The following is a description of a gene set: studied in species Homo sapiens Human Gene Set: GOBP_BLASTOCYST_DEVELOPMENT The process whose specific outcome is the progression of the blastocyst over time, from its formation to the mature structure. The mammalian blastocyst is a hollow ball of cells containing two cell types, the inner cell mass and the trophectoderm. The blastula follows the morula and precedes the gastrula in the developmental sequence., and this is the list of marker genes: YAP1, SUV39H1, CHEK1, ZFP14, CUL3, EOMES, NPM2, CTR9, WDR74, CNOT1, PEMT (phosphatidylethanolamine N-methyltransferase), DAD1, BYSL, NASP, CCDC62, SBDS, RTN4, RBM46, RTF1, STMN3, CNOT2, HS3ST6, SKIL, KDM4C, RRP7A, NECAB1, INTS1, PSMC3, SALL4, GRN, ARHGDIG (NCBI Gene Id 398), BNIP2, LATS2, ZNF830, PSMC4, MED21, PHF6, POU5F1, SRF, UBTFL1, LATS1, PTPN18, BCOR, FBLL1, SUPT6H, PALB2, THOC2, TFAP2C, PELO, GINS1, COPS2, TTLL4, TAF8, ASF1B, PNLDC1, NODAL, ST8SIA6, ETV2, EMG1, GABPA, N4BP2L2, AGBL4, SP3, MFN2, NBN, SOX17, ACVR1C, ADA, CAPN2 (NCBI Gene Id 824), MATR3, KLF4, SLC25A34, ZPR1, NLE1, NEK2 (NCBI Gene Id 4751), RPL7L1, CNOT3, PRPF19, HNF1B, TTLL1, RBBP8, MFNG, CDX2, CCNB1IP1, KPNA7, RPL13, MXI1, BRCA2, SF3B6, ZP3, CCDC24, RAD51B, AKAP3, PPP1CC, HAND1, SMARCB1, ELF3, LPAR6, ACTL6A, TM4SF1, ZBED6, HCFC1, IGF1, PLPP4, RRM2, SPECC1, PPP4R4, NDUFA2, GINS4, XAB2, CITED2, NR5A2, SMIM14, NDEL1, HORMAD1, TET1, FURIN, SPIC, HOPX, JUNB, TGFBR1, NCAPG2, PRDM14, TBL1XR1, SLC35E2B, TEAD4, CMTM3